The following is a description of a gene set: Human Gene Set: CAFFAREL_RESPONSE_TO_THC_24HR_5_DN studied in species Homo sapiens Genes down-regulated in EVSA-T cells (breast cancer) treated with 5 micromolar THC (delta-9-tetrahydrocannabinol) for 24 h. It has been recently shown that cannabinoids, the active components of marijuana and their derivatives, inhibit cell cycle progression of human breast cancer cells. Here we studied the mechanism of Delta(9)-tetrahydrocannabinol (THC) antiproliferative action in these cells, and show that it involves the modulation of JunD, a member of the AP-1 transcription factor family. THC activates JunD both by upregulating gene expression and by translocating the protein to the nuclear compartment, and these events are accompanied by a decrease in cell proliferation. Of interest, neither JunD activation nor proliferation inhibition was observed in human non-tumour mammary epithelial cells exposed to THC. We confirmed the importance of JunD in THC action by RNA interference and genetic ablation. Thus, in both JunD-silenced human breast cancer cells and JunD knockout mice-derived immortalized fibroblasts, the antiproliferative effect exerted by THC was significantly diminished. Gene array and siRNA experiments support that the cyclin-dependent kinase inhibitor p27 and the tumour suppressor gene testin are candidate JunD targets in cannabinoid action. In addition, our data suggest that the stress-regulated protein p8 participates in THC antiproliferative action in a JunD-independent manner. In summary, this is the first report showing not only that cannabinoids regulate JunD but, more generally, that JunD activation reduces the proliferation of cancer cells, which points to a new target to inhibit breast cancer progression. from publication Caffarel MM, Moreno-Bueno G, Cerutti C, Palacios J, Guzman M, Mechta-Grigoriou F, Sanchez C (PMID 18454173), and this is the list of marker genes: RANBP1, NME1, ATP5MF, MLC1, LRRC28, TGFB3, WARS1, SERPINB2, NUSAP1, ALG2, NEAT1, NDUFB3, PCBP2, RRM2, CENPL, EIF5, GARS1, SPINT2, DCTN4, NDUFA1, ZRANB2, SEC16A, RAB2A, CALM3, ATP5MK, MT2A, FXYD3, ASNS, SPIDR, FOXM1, EBP, TYRO3, PCLAF, POLR2J2, PPIH, FTMT, UBR4, EXOC2, POU4F1, ARF4, ATP5MJ, SHMT2, SUB1, H4C3, MCCC1, CDK1, RBM4, UBE2C, TUBA1A, IGFBP5, HERPUD1, DUT, YY1AP1, SLC3A2, IMPA1, COPB2